Given this list of marker genes LAYN, VGLL3, GLRA4, SLC39A8, LDB3, SON, ZNF292, E2F5, PBX3, USP30, CANX, DMRT2, USP32, PRR23C, CENPU, PIM2, ASCC3, GEMIN8, SLC25A31, MIS18BP1, MYT1L, CTCF, VSIG10L, SCLT1, CPEB2, PTBP2 (NCBI Gene Id 58155), SAMTOR, HTATIP2, DIP2A, PTEN, RAB8B, TRMT11, PHLDB2, SOX6, METTL4, RAI14, FMR1, NCK2, MYCN, WDHD1, FAM174B, LRRCC1, GABRG1, ABL2, ERCC6L2, CREBRF, SUZ12, PRKAG2, SHISA2, PLEKHM3, JAKMIP2, ANKRD34B, NR6A1, MGST1, FGF18, EAF1, IL6ST, EPC1, MYH10, MDM1, ESYT2, MELK, CSNK1A1, ACOT4, MIER1, EPDR1, WDR37, GPM6A, GLYR1, UBLCP1, MLXIP, LIMS1, PAFAH1B1, C9orf72, CADM1, SP4, KCNT2, GYG1, KIT, CEP97, ANAPC11, ZNF197, ELOVL4 (ELOVL fatty acid elongase 4), FAM169BP, MEIS2, CACNB4, EMD, BRWD3, MARCHF5, MAPK8, PUM2, MZT1, C2orf72, PLK4, HMGB1, SPINDOC, HIPK1, DHX15, LDOC1, TM9SF2, SLC6A14 (NCBI Gene Id 282807), TBX5, TMEM263, ACTN2, IFNG, HNRNPM, SNX30, EIF3A, SRSF11, ROR1, RBMS3, here is a description of the gene set: Human Gene Set: MIR505_3P studied in species Homo sapiens from publication Chen Y, Wang X (PMID 31504780) Genes predicted to be targets of miRBase v22 microRNA hsa-miR-505-3p in miRDB v6.0 with MirTarget v4 prediction scores > 80 (high confidence targets).